The following is a description of a gene set: species: Mus musculus Genes positively differentially expressed in cell type: eTAC (extrathymic Aire-expressing cell) upon treatment with cytokine: IL-18 in mouse lymph nodes in vivo. Cytokines mediate cell-cell communication in the immune system and represent important therapeutic targets. A myriad of studies have highlighted their central role in immune function, yet we lack a global view of the cellular responses of each immune cell type to each cytokine. To address this gap, the authors created the Immune Dictionary, a compendium of single-cell transcriptomic profiles of more than 17 immune cell types in response to each of 86 cytokines (>1,400 cytokine-cell type combinations) in mouse lymph nodes in vivo. A cytokine-centric view of the dictionary revealed that most cytokines induce highly cell-type-specific responses. For example, the inflammatory cytokine interleukin-1β induces distinct gene programmes in almost every cell type. A cell-type-centric view of the dictionary identified more than 66 cytokine-driven cellular polarization states across immune cell types, including previously uncharacterized states such as an interleukin-18-induced polyfunctional natural killer cell state. Mouse Gene Set: CUI_ETAC_IL18_RESPONSE_UP from publication Cui A, Huang T, Li S, Ma A, Pérez JL, Sander C, Keskin DB, Wu CJ, Fraenkel E, Hacohen N (PMID 38057668), and this is the list of marker genes: Psmb9, Ccl17, Igtp, Ifi47, Stat1